Given this list of marker genes Kcnk4, here is a description of the gene set: part of: Tandem pore domain potassium channels Reactome Pathway: TWIK related potassium channel (TREK) electronically inferred by orthology from the curated human pathway species: Mus musculus This event has been computationally inferred from an event that has been demonstrated in another species.<p>The inference is based on the homology mapping from PANTHER. Briefly, reactions for which all involved PhysicalEntities (in input, output and catalyst) have a mapped orthologue/paralogue (for complexes at least 75% of components must have a mapping) are inferred to the other species.